The following is a description of a gene set: Any process that stops, prevents, or reduces the frequency, rate, or extent of natural killer cell mediated immunity. studied in species Mus musculus Mouse Gene Set: GOBP_NEGATIVE_REGULATION_OF_NATURAL_KILLER_CELL_MEDIATED_IMMUNITY, and this is the list of marker genes: Serpinb9e, Ceacam1, Serpinb9c, Serpinb9f, Clec12b, Tap1, Cd96, Nectin4, Serpinb9, H2-M3, Tap2, Klrd1, Mill1, Lgals9, Grb2 (growth factor receptor bound protein 2), Igf2, Nectin2, Tgfb1, Serpinb9h, Klrb1b, Arrb2, Sh2d1b2 (SH2 domain containing 1B2), Klre1, Serpinb9d (NCBI Gene Id 20726), Crk, Serpinb9b, Gfer, Sh2d1b1, Serpinb9g, H2-T23, Clec2d, Inpp5d, Havcr2